The following is a description of a gene set: species: Homo sapiens Any protein complex that is capable of functioning as a neurotransmitter receptor. Human Gene Set: GOCC_NEUROTRANSMITTER_RECEPTOR_COMPLEX, and this is the list of marker genes: CHRNA6, PTK2B, GRID2, DLG3, EPS8, GRIA3, CHRNA3, CHRNB4, OLFM3, HTR3A, GRIK2, GRIA4, CNIH3, DLG4, GRIN2B, OLFM2, GRIK4, PORCN, SHISA8, CHRNA7, CHRNA2, VWC2, GRIK1, CACNG4, HTR3B, CHRNA4, GRIN3A, HTR3E, GRIA1, NRN1, ABHD12, SHISA6, GRIA2, CHRNB2, GRIN2D, GRIK3, CPT1C, GRIN2A, SACM1L, CHRNB3, GRID1, CACNG5, HTR3C, GRIN1, SHISA9, CACNG7, CACNG8 (NCBI Gene Id 59283), HTR3D, CACNG3, GRIK5, ABHD6, VWC2L, CHRNA5, GRIN3B, CACNG2, CNIH2, SHISA7, GRIN2C